The following is a description of a gene set: species: Homo sapiens Human Gene Set: HP_DECREASED_ACTIVITY_OF_THE_PYRUVATE_DEHYDROGENASE_COMPLEX Decreased activity of the pyruvate dehydrogenase complex, and this is the list of marker genes: ECHS1, DLAT, GLRX5, PDHB, LIAS, SLC39A8, PDHX, MRPL39, PDHA1, PDP1, BOLA3